Given this list of marker genes Sdhb, Sirt3, Iscu, Isca1, Sdhaf1, Fxn, Idh2, Sdhaf4 (succinate dehydrogenase complex assembly factor 4), Acat1, Sdha, Sdhc (succinate dehydrogenase complex, subunit C, integral membrane protein), Nfs1, Sdhaf3, Sdhd, Isca2, Lyrm4, Sdhaf2, Aco2, here is a description of the gene set: Maturation of TCA enzymes and regulation of TCA cycle Mouse Gene Set: REACTOME_MATURATION_OF_TCA_ENZYMES_AND_REGULATION_OF_TCA_CYCLE species: Mus musculus